The following is a description of a gene set: from publication Tabula Muris Consortium (PMID 32669714) species: Mus musculus Mouse Gene Set: TABULA_MURIS_SENIS_PANCREAS_PANCREATIC_DELTA_CELL_AGEING, and this is the list of marker genes: Kdm6b, Ubb-ps, Sdf2l1, Dda1, Ctnnbip1, Ly6h, Wipi1, Dusp1, Rpl13a, Cltb, Depp1, Hras, Ckb, Sf3b2 (splicing factor 3b, subunit 2), Drap1 (DR1 associated protein 1), Tmem263, Nsmce3, Wdfy1, Sil1, Ssr1, Smco4, Cldn4, Gnb1, Zfyve21, Cd63, Mob2, Zscan26, Tle5, Nnat, Hprt1, Zg16, Rsrc2, Cstpp1, Abhd8, C2cd4b, Cpa2, Gadd45g, Mapk15, Prr13, Peg3, Ier2, Itm2c, Dpysl2, Arl6ip5, Dbpht2, Ddrgk1, Lgmn (legumain), Slc25a5, Clps, Gnptg, Nucb2, Ache, Celf3, Klc4, Celf4, Snrpc, Tsc22d1, Ube2e1, Sfrp5, Cela1, Szrd1, Lgals3bp, Mospd3, Ccn1, Pip4p1, Epcam, Tubb2b, Rab37, Sfr1, Mettl26, Ywhae, Hhex, Map1lc3a, Coro1b, Fkbp3, Dnajb1, Hook2, Pick1, Arglu1 (arginine and glutamate rich 1), Rpl6, Fbxl16, Selenos (selenoprotein S), Aco2, Tmed9, Smarcb1, Ccdc92, Nadsyn1, Pea15a, Egr1, Fam241b, Ptov1, Alkbh6, Morf4l1, Fxyd6, Il11ra1, Tmem250, Znhit1, Eif5a, Scg5, Elof1, Ccdc124, Hmces, Herpud1, Gsn (gelsolin), Zfp36, Rbm39, Ogfod3, Cadm1, Adrm1, Tspan8, Fkbp8, Tomm40l (translocase of outer mitochondrial membrane 40-like), Dusp7, Calm2, Pebp1, Jund, Ubb, Cd151, Akt1s1, Impact, Tmem59l, Hadh, Pdia5, Cotl1, Tdrkh, Fos, Rhoc, Sod1, Txnl4a, C1qa, A330076H08Rik, Cltrn, Rab3b, Set, Kazald1, Junb, Gabarapl1, Prrg2, Cela2a, Tex261 (testis expressed gene 261), Polb, Rtn4, Srsf11, Il6ra, Pabir1, Ush1c, Golga7b, Jun, Rae1, Prss2, Rbm26, Eri3, Oaz1, Aamp, Cirbp (NCBI Gene Id 97676), Rheb, Sez6l2, Manbal, Rogdi, Mapre3, Laptm4a, H3f3b, Inpp4a, Try4, Pcbp3, Tubb4b, Ptms, Itgb8, Sdc4, Ptpa, Slc25a3, Ctrb1, Srsf5, Krt8, Ddhd2, Ubc, Ptpn1, Nbl1 (NBL1, DAN family BMP antagonist), Bsg, Rgs16, Ece1, Wbp2, Mmp24os1, Mtcl3, Cldn7, Cfl1, Pcsk1n, Tmem59 (NCBI Gene Id 76986), Sult2b1, Ninj1, Gstm1, Hdgf, Pnrc1, Pex26, Tceal3, Dnaja1, Arf1, Arhgdia, Sdhc